The following is a description of a gene set: studied in species Mus musculus Mouse Gene Set: GOBP_PHOSPHOLIPASE_C_PROTEIN_KINASE_C_SIGNAL_TRANSDUCTION An intracellular signaling cassette that starts with activation of phospholipase C (PLC) activity and ends with the activation of protein kinase C (PKC). PLC produces inositol 1,4,5-trisphosphate (IP3) and diacylglycerol (DAG). IP3 regulates the opening of calcium channels in intracellular calcium store, leading to the release of calcium into the cytosol. Calcium and DAG activate protein kinase C (PKC), which in turn activates downstream effectors. This cassette is often part of the phospholipase C-activating G protein-coupled receptor signaling pathway., and this is the list of marker genes: Ankrd1, Edn1, Plcd1, Csrp3 (cysteine and glycine-rich protein 3), Dgkg, Dgkd, Prkch